Given this list of marker genes BTD, MCCC2, PCCA, PC, MCCC1, ACACA, PCCB, HLCS, here is a description of the gene set: part of: Defects in vitamin and cofactor metabolism Reactome Pathway: Defects in biotin (Btn) metabolism Biotin (Btn, vitamin B7, vitamin H, coenzyme R) is an essential cofactor for five biotin-dependent carboxylase enzymes, involved in the synthesis of fatty acids, isoleucine, valine and in gluconeogenesis. Thus, Btn is necessary for cell growth, fatty acid synthesis and the metabolism of fats and amino acids. Inherited metabolic disorders characterized by deficient activities of all five biotin dependent carboxylases are termed multiple carboxylase deficiencies. Two congenital defects in biotin metabolism leading to multiple carboxylase deficiency are known, holocarboxylase synthetase deficiency (MIM 609018) and biotinidase deficiency (MIM 253260). In both scenarios symptoms include ketolactic acidosis, organic aciduria, hyperammonemia, skin rashes, hypotonia, seizures, developmental delay, alopecia, and coma. As humans are auxotrophic for Btn, the micronutrient must be obtained from external soures such as intestinal microflora and dietary forms. Accordingly, severe malnutrition can also give rise to biotin deficiency and multiple carboxylase deficiency. Biotin deficiency can also be induced by the excessive consumption of raw egg white that contains the biotin-binding protein avidin. Holocarboxylase synthetase deficiency arises when all five biotin-dependent enzymes are not biotinylated leading to their reduced activities. The defective genes causing these conditions are described here. Biotinidase deficiency is caused by defects in the recycling of Btn. General symptoms include decreased appetite and growth, dermatitis and perosis. The defective genes causing these conditions are described here.<br> studied in species Homo sapiens